Given this list of marker genes PTPN1, EPN2, MMRN2, NEDD4, HGS, DAB2IP, MIR200C, MMRN1, PDCD6, HHEX, CADM4, EMILIN1, here is a description of the gene set: Any process that stops, prevents, or reduces the frequency, rate or extent of vascular endothelial growth factor receptor signaling pathway activity. studied in species Homo sapiens Human Gene Set: GOBP_NEGATIVE_REGULATION_OF_VASCULAR_ENDOTHELIAL_GROWTH_FACTOR_RECEPTOR_SIGNALING_PATHWAY